Given this list of marker genes Dvl3, Rac1, Csnk1d, Wnt3, Sfrp2, Wnt1, Wnt9b, Ctnnb1 (catenin beta 1), Lmx1a, Ryk, Wnt2, Wnt5a, Sfrp1, Dkk1, here is a description of the gene set: species: Mus musculus The process in which a relatively unspecialized cell acquires the specialized features of a midbrain dopaminergic neuron. Mouse Gene Set: GOBP_MIDBRAIN_DOPAMINERGIC_NEURON_DIFFERENTIATION